Given this list of marker genes CHAT, FKTN, MYH7, SELENON, SNAP25, SLC25A1, CFL2, EMD, SCN4A, SYT2, SNUPN, AGRN, MYBPC1, ACTA1, JAG2, DYSF, SLC5A7, INPP5K, COL13A1, KY, HSPG2, ACVR1, DNAJB4, SLC18A3, TPM2, COL2A1, MYO9A, LMOD3, ERLIN2, TNNT1, SYNE1, COL6A2, MYPN, NEB, COL12A1, COL6A1, KLHL41, MYMK, SYNE2, LMNA, VAMP1, POMT2, CAPN3, BAG3, TTN, PYROXD1, CAVIN1, FILIP1, TOR1AIP1 (NCBI Gene Id 84764), TRIP4, TNPO3, ADAMTS15, DES, KBTBD13, TMEM43, FHL1, TPM3, ORAI1, COL6A3, POMT1, MGME1, here is a description of the gene set: Spinal rigidity Reduced ability to move the vertebral column with a resulting limitation of neck and trunk flexion. species: Homo sapiens Human Gene Set: HP_SPINAL_RIGIDITY